Given this list of marker genes PTCH1, NOTCH1, RBPJ, FOXI3, PTCH2, here is a description of the gene set: The process in which a cell becomes capable of differentiating autonomously into an epidermal cell in an environment that is neutral with respect to the developmental pathway; upon specification, the cell fate can be reversed. species: Homo sapiens Human Gene Set: GOBP_EPIDERMAL_CELL_FATE_SPECIFICATION